Given this list of marker genes Birc5, Incenp, Aurkc, Cdca8, Aurka, Aurkb, here is a description of the gene set: Mouse Gene Set: GOCC_CHROMOSOME_PASSENGER_COMPLEX species: Mus musculus A eukaryotically conserved protein complex that localizes to kinetochores in early mitosis, the spindle mid-zone in anaphase B and to the telophase midbody. It has been proposed that the passenger complex coordinates various events based on its location to different structures during the course of mitosis. Complex members include the BIR-domain-containing protein Survivin, Aurora kinase, INCENP and Borealin.